Given this list of marker genes SMC2, TIMP2, ARHGAP29, OTULIN, TET3, GASK1B (NCBI Gene Id 83936), ASB7, MAML2, STRN, CCSAP, APBA1 (amyloid beta precursor protein binding family A member 1), RBM4, OCIAD1, KCNK9, TNFSF10, COL4A1, RBM14-RBM4, PAK1, TSPAN7, FAM193A, TFCP2L1, NMT1, SETBP1, CTNNB1, TRAPPC13, NXT2, N4BP2, FSTL5 (NCBI Gene Id 96018), CRYGS, KRT19, HAS3, C10orf90, KRT8, CAV1, DSTN, MXD1, FAF2, FOXO1, CCNJ, GOLPH3, ITCH, IPO11, RIMS2, CRB1, ARL4A, MED13, SAR1A, here is a description of the gene set: Human Gene Set: MIR4776_5P Genes predicted to be targets of miRBase v22 microRNA hsa-miR-4776-5p in miRDB v6.0 with MirTarget v4 prediction scores > 80 (high confidence targets). species: Homo sapiens from publication Chen Y, Wang X (PMID 31504780)